The following is a description of a gene set: Human Gene Set: BRUINS_UVC_RESPONSE_LATE Late response genes: differentially expressed only 12 h after UV-C irradiation of MEF cells (embryonic fibroblast). from publication Bruins W, Bruning O, Jonker MJ, Zwart E, van der Hoeven TV, Pennings JL, Rauwerda H, de Vries A, Breit TM (PMID 18195040) species: Mus musculus Phosphorylation is important in p53-mediated DNA damage responses. After UV irradiation, p53 is phosphorylated specifically at murine residue Ser389. Phosphorylation mutant p53.S389A cells and mice show reduced apoptosis and compromised tumor suppression after UV irradiation. We investigated the underlying cellular processes by time-series analysis of UV-induced gene expression responses in wild-type, p53.S389A, and p53(-/-) mouse embryonic fibroblasts. The absence of p53.S389 phosphorylation already causes small endogenous gene expression changes for 2,253, mostly p53-dependent, genes. These genes showed basal gene expression levels intermediate to the wild type and p53(-/-), possibly to readjust the p53 network. Overall, the p53.S389A mutation lifts p53-dependent gene repression to a level similar to that of p53(-/-) but has lesser effect on p53-dependently induced genes. In the wild type, the response of genes to UV irradiation was strictly biphasic. The early stress response, from 0 to 3 h, results in the activation of processes to prevent the accumulation of DNA damage in cells, whereas the late response, from 12 to 24 h, relates more to reentering the cell cycle. Although the p53.S389A UV gene response was only subtly changed, many cellular processes were significantly affected. The early response was affected the most, and many cellular processes were phase-specifically lost, gained, or altered, e.g., induction of apoptosis, cell division, and DNA repair, respectively. Altogether, p53.S389 phosphorylation seems essential for many p53 target genes and p53-dependent processes., and this is the list of marker genes: DIXDC1, AGRN, BCR, SAP30L, STX8, DMAC2L, BEX3, STXBP5, TNC, USP17L24, PSMC2, ACP6, RNF121, COQ7, DISP1, ADH5, CLNS1A, CTHRC1, PAIP1, DNAJB1, MSRB1, TRAM1, MRE11, ZNF326, PTN, MUS81, TUBA1A, RGS7, ACTA2, MTCH1, HDGFL2, ASF1B, TEX261, ZNF593, MLLT10, PSPH, GSK3B, TJP2, FAM114A2, INSL6, PLAC8, HNRNPDL, RMND5B, SLC17A9, MFAP4, NDUFAF7, CSNK2A1, TUSC3, CCDC22, NDUFAF3, TOB1, SASS6, SH2D1B, XRCC1, PGPEP1, PPIL2, CENPU, ALOX5, MIF4GD, GJB5, UGT2A1, REST, CCNH, FBXO7, RFC3, PDK4, ACOT9, PCMT1, CCDC178, IDI1, ANO1, FN1, CDK5RAP1, SDHAF3, DAPK1, ARHGEF1, TSG101, CIBAR1, MOS, DSCC1, DPEP1, UCK2, DCAF7, PDRG1, PCOLCE, NFS1, HSF1, LIAS, WASHC3, FAM89A, CCDC88C, FADS2, PSMD4, PTPRS, CYTIP, MFAP5, RP2, NPM1, MTX2, SLC22A15, DDX6, TMIGD1, EPHA1, PITX1, RPF2, VPS36 (NCBI Gene Id 51028), ARL8B, SPDYE4, ST3GAL6, CSRP1, MYL6, EXOSC8, UFM1, GLYAT, DDX19A, COPS4, GSTT3P, PPM1M, MLKL, SGCD, SEPTIN11, ACOX2, DOCK2, TFPI2, LOXL1, ELDR, METTL5, COMMD9, TNIP1, MAD2L2 (mitotic arrest deficient 2 like 2), C1orf131 (chromosome 1 open reading frame 131), UBE2E3, HOATZ, C16orf74, AP3S2, LRRC8D, PIKFYVE, ABCG8, NDUFA1, LTB4R, AFDN, FAM83D, HOXB3, UHMK1, FTO, PRKAR2A, P3H4, KRT12, STX4, TEX30, MTAP, WHRN, SARS2, SEMA7A, ATOX1, UCHL3, OXCT1, RNF138, ATL3, GEMIN2, TLR4, PTPN11, BLVRA, HPCA, NUP93, TEX9, PDCD10, OCIAD2 (OCIA domain containing 2), PTPRZ1, PSD3, DIAPH2, ZNF131, LOXL3, OR2Y1, PCCB, IFI35, TIMM21, CLN3, DONSON, DNAJC18, DKK2, MYO1H, LPAR6, UBAC2, RIOX1, CTBP2, CAMKMT, PPP6R3, TAPBP, GPATCH2, UBE2T, SSBP1, PPIC, ATP6V0D1, AARSD1, HPCAL1, RABEP1, CCNDBP1, ATP6V1G2, GGCX, PSMC1 (proteasome 26S subunit, ATPase 1), VPS33A, PAGR1, VAMP4, PPP1R13B, DNAJA4, COL5A2, ATP6V1C1, HSPA14 (heat shock protein family A (Hsp70) member 14), CMIP, TSC2, CTU1, OSBPL3, NT5DC2, TFCP2L1, MCL1, SERPINB8, CAV1 (NCBI Gene Id 857), MCM3, TWSG1, TAOK3, FAM114A1, SPEM1, MIPEP, XRN2, CD8B, AIFM1, CRABP1, PPP1R3F, GAP43 (NCBI Gene Id 2596), DNAJC15, ASPN, EFCAB15P, DNAJC5, GTF2A1, ST6GALNAC5, NMT2, DOCK7, HYAL2 (hyaluronidase 2), GGCT, AKAP8L, PHF10, PACSIN2, PPAT, TOMM34, MTMR9, TNFRSF10B, KLHDC8A, SMIM8, SLC31A1, TRIP4, PGP, KPNA4, CHCHD3, LOXL2, STOML2, PRPF40A, ZBED3, OGN, GNPDA1, LRIG3, ATP6V1D (ATPase H+ transporting V1 subunit D), GSTO2, GJB3, RNF38, AJUBA, METAP1, FAM83G, HEMK1, WASHC1, SGSM3, TMEM127, DBNL, CKMT1B, PDXK, SURF2, CYP27A1, AATF, PARM1, KDSR, COL1A2, CAST, NECTIN3, VASN, BTF3L4, STIMATE, NUDT4, KRIT1, CMTM3, RRAD, ALS2, SIK3, VEGFC, GINS4, TPMT, CCDC86, C6orf120, CDPF1, NID2 (nidogen 2), HTRA2, RNF225, DUT, B4GALT3, EMC8, GDE1, SSU72, AIMP1, ATPSCKMT, FABP5, NDUFS3, ATP2B1, TCF19, SLC35B1, ETNK1, SETDB1, RASSF7, RNASEH2A, WWTR1, CTNND2, SPRR1B, RPP30, FARP1, GTF2F2, GCSH, MYH10, ODF2L, PSTPIP1, SLC44A1 (NCBI Gene Id 63942), MLYCD, DKK3, SOCS2, PRKAR1A, CASP8, NID1, FBXW4, PDF, MRPS28, EBNA1BP2, APP, EIF2B1, CEACAM21 (CEA cell adhesion molecule 21), IKBIP, ROM1, BLOC1S2, PIAS2, CEP131, CD2BP2, PSMD12, FAM241B, PLSCR1, HAUS8, ZW10, NGF, TMEM65, EAF1, MNAT1, PPP1R12A, SMIM20, RIN1, PSMD14, MTM1, PXDN, DUBR, ATIC, CXADR, MRPS18A, EZH2, ANXA1, HMGA2, PIP4P2, COL4A5, CALU, NUP43, MEG3, IFTAP, PIN4, STX18, SCAMP5 (NCBI Gene Id 192683), ASCC2, SNAP29, CCDC47, ARSB, INTS13, ABHD6, E2F1, MUSTN1, ATG9B, GEMIN6, PSAT1, PIWIL1, CHAF1A, ZFAND6, SGMS2, MRPS34, NAT9, SH3D21, TMEM176A, NQO2, CRISPLD2, CMC2, GNB1L, MXRA7, CMAS, COMMD10, DSN1, VAMP5, COL6A3, KRT20, ATP6V1H, USE1, ANXA6, CD2AP, YKT6, DDX55, TANK, TBATA, ADAT2, CHEK2, PRSS23, STEAP3, SIL1, KRT13, PPIL3, AGPAT5, TTC39C, CHIA, POLE2, TRIM15, UNC5CL, COL1A1, MAP4, SORCS1, PSMD10, LTBP4, ADRB2, TBC1D7, RBMS1, CD40, GRB10, PER1, CDK9, MOCOS, PTPRM, NOVA1, KLHDC10, OCEL1, MEIKIN, QRSL1, GATM, NMT1, HSD3B7, GKN1, ANKRD1, MRPL33, ICAM5, MYO5C, HIKESHI, HAT1, CPA4, RAB20, RSU1, BCAS2, TRAPPC6B, H2AX, CDK16, TMEM183A, DGKA, TARBP2, BCS1L, TTC17 (tetratricopeptide repeat domain 17), SEPTIN9, MRPL17, MECR, MED6, HAUS4, SMURF1, ABCB8, RBMS3, GIPC2, FAH, HSD3B2, FLT1, UBAP2, ATP6V1E1, POGLUT3, SRPX, IL15, ELOC, URAHP, ERAP1, SPA17, DKKL1, CFDP1 (NCBI Gene Id 10428), MMP23B, SUDS3, SLC25A14, GTF2E2, CDC45, ZNF267, PCGF5 (polycomb group ring finger 5), MOK (MOK protein kinase), BET1, BMAL1, DRG1, PFN4, CDK1, TSPAN5, GATAD2A, BRCC3, AKIP1, ATXN7, ATF5 (NCBI Gene Id 22809), ZCRB1, ECHDC1, OSBPL9, FBF1, ARHGAP27, AAMDC, UBE2B, COL11A1, ARHGEF7, ERAL1, NAB1, NBN, NEIL1, PAPOLA, ABHD5, PEX14, PTPN22, CHMP1B2P, PPBP, CD302, TBCD, TIPIN, C8orf88, EXO5, ANGPT2, CHST14, SLC12A2, RALA, KCNAB3, RP9, FIG4, VPS26B, ENO3, GPS2, RNF31 (NCBI Gene Id 80191), PSMA5, ACTG1 (actin gamma 1), SNX1, MRPL15, SWAP70, MEMO1, PYCR1, TBP, PPCDC, MATN2, IMPA2, SPOP, GZMH, PEX7, BMPR2, OR2D3, PRR5L, CCND2, EMC2 (NCBI Gene Id 9694), ATG4B, EXOC3L4, VN1R5, ROGDI, SYP, KDELR3, KIF3A (kinesin family member 3A), CYGB, SAMD8, NMU, PDE4B, PEX3, CFAP298, PKD1, DPP8, MIB1, DAAM2, GNG11, STAT6, IMMP2L (inner mitochondrial membrane peptidase subunit 2), DCK, MPLKIP, HIC1, SPATC1, TTC7A, RCN1, TADA3, TMEM86B, CA13, AIFM2, C11orf98, NUBPL, PSMG1, CMC1, WDR54, PRSS44P, TPD52L1, ACOT13, RBPJ, EEF2KMT, ZCCHC17, ACSS2, ABCB1, SMC5, COL11A2, PSMA1, CST6, FMO5, HRH3, NFU1, SRD5A3, LRRC28, TMBIM6, NANS, AREG, RPAP3, MEAF6, CFAP410, TOMM5, LTB4R2, P4HA1, FER, C20orf144, OSTC, CCL21 (C-C motif chemokine ligand 21), NUDT5, PRIM1, XIRP2, UCHL5, FKBP1A, HERC6, SLC25A16, CHPT1, GRIN2D, MAP3K7, ACCS, LOX, TPM1, ADGRA2, FDX1, LCMT1 (NCBI Gene Id 51628), MCM4, FBXO6, KIFC3, CEP85L (centrosomal protein 85 like), MYL12A, DYNAP, DCBLD2, PHF6, VRK3, COL6A1, TRMO, HOOK2, REXO5, SLC46A1, WARS2, CSNK1G3, NTHL1, RGS17, RUFY1, SELP, TLN2, HS3ST1, ELK3, TGFA, SLC48A1, NTNG2, LAMA4, IPP, STX12, TEAD4, CHAF1B, ANP32B, SPAST, SIN3B, CELSR3, CLIP1, MYOM1, CHRNE (NCBI Gene Id 83405), MMP19, MTARC2, TCTN3, LDLR, AAGAB, COA3, ACY3, ATG7, NAB2, ITGB4, C1orf35, SLK, KDM6A, FRG1, CUX1, CCDC181, CYRIB (CYFIP related Rac1 interactor B), C15orf40, CD38, SRPRB, ACTB, COLEC12, KIAA0040, IL17A, CIAO1, FBXO8, CCDC13, DNAJC24, EXT1, WTAP, DVL1, DNMBP, AHR, KLF13, CDA, LRRFIP2, UBE2K, GHR (NCBI Gene Id 2690, growth hormone receptor), OSGEPL1, METTL6, STRADA, SUMO2, TGFBI, NUDT21, PTTG1, MFAP3L, CPQ, WWOX, STK4, MRPL18, C22orf23, HACD4, TPRKB, CAB39, TTN, NSMF, C17orf75, GKAP1, MRPS22, WDR5, CREM, SLCO3A1, AHCYL1, NPC1, POR, GREM1, POLM, CCDC34, TOMM20, MFSD2A, PLET1, AGMAT, FSTL1, PNKP, TUBB6, ELOVL7, CSTPP1, ZNF777, CCDC80, SNRPD1, ZCWPW2, ANGPTL4, MGST1, GCLM, TOM1, MMP10, GDF3, KIFAP3, CISD1, RFC4, COL5A1, ACADSB, EPS8L2, DRAP1, BOLA1, KCTD20, DNTTIP1, VPS26C, KLHL13, MBNL2, CITED2, TPST1, SMG9, PLXDC2, CLPB, SIAE, MCM2, QNG1, G6PD, TALDO1, PLIN3, FBXO43, ALOXE3, FABP1, FNTA, LMNB1, SHC1, TUBG1, MYO7A, TK2, RHOB, GSTZ1, CACNA1C, COPZ2, C6orf118, HMG20A, KLK5, RBX1, TOLLIP, TMEM41B, TRMT10B, NNMT, PA2G4, NECTIN1 (nectin cell adhesion molecule 1), GCH1, UTP11, RASA2, TBC1D1, ENPP1, UFSP2, FBLN5, NIT1, TMEM192, KANK3, SEMA3E, SPTLC1, SDCBP2, KRT1, PTPRG, PTGR1, DTD2, DNAJC7 (DnaJ heat shock protein family (Hsp40) member C7), RWDD1, PRKCA, DIABLO, MRPL49, PSMA4, RAD51, MYH6, STAM2, CRTAP, ST3GAL4, FGFRL1, GYG1, TPR, ADAM23, RAB10, GRHPR, ORMDL1, NMI, RPL22L1, B4GALT1, NSMCE1, GZMM (NCBI Gene Id 3004), CPXM1 (NCBI Gene Id 56265), C11orf24 (chromosome 11 open reading frame 24), ITGB3BP, SGCE, FAM117B, PLEK2, SERPINB9, PREB (prolactin regulatory element binding), DNAAF9, UQCRC2, RUVBL1, HMCES, MYH11 (NCBI Gene Id 4629), STK11, ITPR2, SHISA9, RBM3, CSTF2, IER3IP1, NDUFAF6, IQCH, RIMS1, PRKG2, COASY, CD55, CENPK, CCDC90B, MSH5, SYTL1, PLPP1, CTF1, P3H1 (NCBI Gene Id 64175), UBQLN1, USP47, LMTK2, PTX3, COL12A1, PCDH12, ENDOD1, RBL2, MYO5A, MAGOHB, XPO4, MAP1LC3B, ELMO2, NTSR1, OFD1, PTPN21, PGM1, NBAS, EVA1C, ABCG1, SH3BP5L, COL4A1, MMP13, CENPV, GLOD4, TARDBP, HFE, KRT16, TEX2, LRRC17 (NCBI Gene Id 10234), DNAAF8, MARK3, IKBKE, POLA1, DYRK1A (NCBI Gene Id 1859), PTPRK, VAC14, RMDN1, SDR39U1, GLA, MRNIP, AKR1B10, AGK, BCAS3, DPH5, GPC4, HDHD2, APOBEC3B, PSMB7, EPG5, PRNP, USP12, ARAF, EPS8, ARL6, PACRGL, CAPN1, CXCL14, NCAPD2, OGFOD3, MAN1A1, MMP3, RIOK3, NELFE, VTA1 (vesicle trafficking 1), MRPS9, TCEAL1, TCF4, RAB31, RCAN3, ARPC5L, SARNP, CBR4, GALNT2, RTRAF, HSDL2, TRIM21, CDC14B, PLS3, GMPR2, MED15, TFF1, METTL1, PWWP3A, EID3, SCARB2, NPTX1, BUB3, NUDT14, CHMP4C, CZIB, MSRA, TIAM2, MS4A10, PLEKHB2, SHQ1, DDX59, DPY30, LMO1, RPAIN, C11orf52, ECHDC2, SULT4A1, GJB4, MAN2C1, PAK1, RSPH9, MYL9, SLC16A7, LTBP3, THAP9-AS1, POLR2J, NADK2, ADSL, DUSP19 (NCBI Gene Id 142679), GPX7, PTP4A2, P3H3, CCDC103, YWHAB, IRX2, BICC1, GIT2, BMPER, ROBO3, ABTB3, HPRT1, KRT23, JAK2, RAB2A, AOX3P, ARL3, GASK1B, P4HB, RLN2, DOK4, HRAS, CNNM2, CALM2, WNT11, P2RX6, ASPH, DHRS7B, TRAPPC2, SCNM1, PRELID3B, RTKN, C11orf97, TPM2, VAV2, ARHGAP17, SFRP1, NKIRAS1, RFTN1, EFEMP2, DDAH1, FTL, TLN1, MED26, DYNLT2B, NEDD4, TMEM123, ACSL4, SMOC2, BCL2L15, AMACR, SLIT2, PLIN4, APH1B, SRRD, KIAA1210, TIMM44, UBA2, TMEM126B, MCM5, HINT3, EXOSC3, RSRC1, FGD6, RPA1, CNN1, SLIT3, MSH2, SORCS2, SPECC1L, AHNAK (NCBI Gene Id 79026), SVEP1, ATXN3 (NCBI Gene Id 4287), PDIA5, RETSAT, SLC8A1, DOHH, PIGQ, CERS4 (ceramide synthase 4), MTHFD2, PICK1, PFKFB3, ACTA1, TSEN15, JADE1, SUGT1, UBE3A, PIGP, UNK, DPM1, PTEN, CCNE1, COG1, ABCD1, OR10J5, TMEM126A, COX7B2, UBE2J1, AMMECR1L, PDE6D, SNX27, PDIA6, TRAPPC5, SQSTM1, CRNDE, BCL6, TMEM238, ZBTB9, TGFBR2, ATP6V0A2, ESD (esterase D), LGALS8, HMOX2, YARS2, GAPDH, POLR3GL, CCNL2, THBS2, FKBP7, SETD6, PLA2G2D, COL4A2, SLC25A20, UBE2R2, PARVA, HTATIP2 (HIV-1 Tat interactive protein 2, NCBI Gene Id 10553), SLC4A7, FXR1, SNX5, FMOD, KLF10, SOS1 (SOS Ras/Rac guanine nucleotide exchange factor 1), GABRB1, MRPS18C